Given this list of marker genes MON2, RORA, PLN, PGM2L1, PPM1A, ADAMTS6, PAH, FEZF1, RYBP, PROM2, NDUFA5, MAP3K2, PDE4D, CHAD, HSD17B13, PEX13, PGAP1, AGL, USP30, KIRREL1, PIGK, SEC23A, EXOC7, MED13, RBM26, CDH19, ZNF493, BMP2, RFPL1, SRSF2, FLRT3, RNF214, ZEB1, WDR20, COG5, LRCH2, PDE8B, MKX, FOXO1, ACSL6, RC3H2 (ring finger and CCCH-type domains 2), COL4A1, ATP11C (NCBI Gene Id 57206), PDE4B, HSPH1, TENM1, GRAMD1A (NCBI Gene Id 57655), ZNF521, TRPV3, SON, HOXD8, DENND1B, MRPS6, DMAC1, WBP4, RSF1, CDYL2, PLXNA2, FPGT (NCBI Gene Id 8790), FBXL3, TNRC6A, RGS7BP, VAV3, GNL3, PAQR3, DYRK2, PTPN21, ZER1, KIF20A, UBAP1, VWA5A, CAPZA1, POLR2M, SHISA6, FOXN2, ZKSCAN3, GOPC, ABCD3, NETO1, CBX4, STK38L, MMD, PCDH10, RIMKLB, IDI1, FGF18, MINDY2, PRDM1, UBA6, PREX2, ALKAL2, ELOVL7, PARP8, HOXB3, UBE3A, SP3, IFNG, HES1 (hes family bHLH transcription factor 1), TBC1D9, NCOA2, SMAD6, GRAMD1B, TAFA2 (NCBI Gene Id 338811), NPY1R, GPSM2, ADAMTS3, C11orf58, CEBPG, MGAT4A, ABHD18, VEGFC, KHDRBS2, RAB11FIP2, PMP2, EYA1, ZFHX4, TLL2, SEZ6, BICD2, COX15 (NCBI Gene Id 1355), TBC1D23, BACE1, GCOM1, FAM161A, ADCY5 (adenylate cyclase 5), DBR1, STXBP5, TBX4, NUMBL, RASSF8, ZNF423, RBSN, WSB1, NEUROD1, SPDYE3, COL4A6, PNRC1, GLG1, INHBB, TJP1, YTHDF3 (YTH N6-methyladenosine RNA binding protein F3), ZNF345, PALS2, DESI1, GBX2, SCN5A, CCNE2, UBAP2L, CUX1, MBNL2, RAB10, PRDM11, CHSY1, ACLY, PCDHA8, ATF2, SPICE1, PAPPA, DR1, PHACTR3, RANBP9, BNIP2, CFAP418, MAP3K7, NEUROG2, VSTM2A, TMEM245, RNF44, ZSWIM6, TRAPPC8, MZT1, RBPJ, NIPBL, ITGA4, CNTNAP4, N6AMT1, FCAMR, JMY, EFNA5, CFL2, PLD5, LIN28B, CASK, FAF2, CHD7, RRP15, HOMER1, EGR1, SH3TC2, C11orf71 (NCBI Gene Id 54494), GNB2, CCL22, NR2F2, SPAG7, KL, DDX52, ARID2, OCIAD1, CILK1, DMD, ADNP, FNIP1, HAO1, CEBPA, PELI1, LTBP1, CADM2, HCN1, RFPL2, MCFD2, AMZ1, RAB5B, FAM135A, CCDC122, CDK19, TAGAP, ANKRD44, GJC1, SUPT4H1 (NCBI Gene Id 6827), PAXIP1 (NCBI Gene Id 22976), ARHGAP5, FZD6, GRIK1, DSG2 (NCBI Gene Id 1829), ZNF771, NCK1 (NCK adaptor protein 1), SETD2, GCA, KLF7, TMEM108, EPHA5, TCF4, GABRG2, MAPRE1, JMJD1C, MYOZ2, ZNF711, FNBP4, SNRPC, MYLK4, RAB39A, DSG3 (desmoglein 3), RFX4, MAP2, LCOR, KNTC1, SEMA5A, RC3H1, FZD5, RELCH, PTBP1, MLX, CEP20, EIF4G3, BIRC3, EID2B, RUBCNL, LIN7A, ZFR, MECP2, YAF2, RAI1, ARL2BP, PTPN12, GPN3, TAF1A, RNF38, DSN1, CAPZA2, LRRC40, EP300, MBLAC2, DENND4A, PTPN14, DEPDC1, RFK, CEBPB, MTREX, CEP350, PHACTR2, SGPP1, LCA5, YTHDF1, SLITRK1, ARHGAP28, TLE4, SLC7A11, C5orf24, PRRC2C, TMEM117, CPOX, ADAM10, CENPK, NYAP2, ZNF236, DLG3, DYRK1A, NF1, CDKL5, ZNF281, SKI, here is a description of the gene set: studied in species Homo sapiens Genes predicted to be targets of miRBase v22 microRNA hsa-miR-369-3p in miRDB v6.0 with MirTarget v4 prediction scores > 80 (high confidence targets). Human Gene Set: MIR369_3P from publication Chen Y, Wang X (PMID 31504780)